The following is a description of a gene set: Mouse Gene Set: TABULA_MURIS_SENIS_LUNG_VEIN_ENDOTHELIAL_CELL_AGEING studied in species Mus musculus from publication Tabula Muris Consortium (PMID 32669714), and this is the list of marker genes: Pcp4l1, H2-Aa, H2-Eb1, H2-DMa, Cldn5, H2-Ab1, Mapt, B2m, Cd74, H2-DMb1